The following is a description of a gene set: Human Gene Set: REACTOME_SARS_COV_INFECTIONS SARS-CoV Infections species: Homo sapiens, and this is the list of marker genes: IGHV3-53, ANO5, IFIH1, RPS14, IKBKG, ST3GAL2, CHD4, NUP88, PPIA, GPC3, AKT2, NMI, SIKE1, ATP1B2, JAK1, PIK3C3, IGKV1D-39, SFTPD, TRIM4, AAAS, STT3B, AKT1, GATAD2A, TOMM70, IGHV4-39, PPIH, NUP160, RPS5, PDPK1 (NCBI Gene Id 5170), RPS19, BRD4 (NCBI Gene Id 90616), RPS3, ISCU, NUP58, CHMP4A, RPS23, OST4, FAU, PARP4, UBE2I, CD79B, EEF1A1, UBA52, JAK2, IGLV2-14, TLR2 (NCBI Gene Id 7097), IGLV3-1, IGLV2-8, IMPDH2, IGLV1-51, PCBP2, CHMP6, NUP133, RBBP4, IGLV1-40, RIPK1, RPS29, VPS16, B2M, IFNAR2, TRAF3, NUP107, SDC4, IFNA10, IGHD, IFNA13, TRAF6, RPN2, CHMP3, SAP18 (NCBI Gene Id 10284), BECN1, IFNA21, RPS24, DDX5, FURIN, MOGS, G3BP1, IGKV2-28, PRKCSH, PARP9, PATJ, SMN1, RPN1, RIPK3, GALNT1, TAB1, DDOST, IGHV1-2, GSK3A, STT3A, TMPRSS2, IGHV1-69, HSPG2, HSP90AA1, RPS12, HMG20B, IMPDH1, NUP85, IGKV1-39, IGLV3-25, RPS16, IRF7, ZDHHC5, HLA-C, TJP1, ZBP1, RANBP2, ZDHHC3, FUT8, MAGT1, MGAT4B, IGKV1-5, DAD1, IGKV1D-12, SEH1L, TKFC, CASP1, RPS28, IFNA17, LARP1, UBB, RBX1, KPNA2, IRAK1, TPR, MGAT5, HLA-F, SEC24A, ARID4A, IGKV1-16, GPC1, RPSA, HLA-G, ST6GALNAC4, MTA3, TAB3, ST3GAL1, YWHAZ, STING1, IGKV4-1, SMN2, IGHM, SAP30, RAE1, PARP14, ATG14, ZDHHC2, RPS11, NLRP3, SERPINE1, TLR7, SMAD4, IL17RA, CD79A, RPS2, MTA2, HDAC2, NUP42, NUP93, IGKV3-11, IGLV6-57, CHMP2B, RB1, RPS4X, IGLC2, OSTC, SEC23A, ANO8, BST2, IGHV3-13, MAN1B1, GEMIN7, RPS27L, IGKV5-2, MGAT2, NUP214, NDC1, CHD3, CHUK, IFNA16, IGHV3-48, IGHV2-5, STAT1, SOS1, FXYD4, RCAN3, CANX, RPS3A, ATP1A3, RELA, HNRNPA1, FXYD1 (FXYD domain containing ion transport regulator 1), RIPK2, SH3KBP1, HLA-A, SNRPD3, TLR8, FXYD3, RPS6, RPS26, FNTA, CHMP2A, VPS33B, ATP1A2, EP300, SNRPF, CUL3, SUMO1, HSP90AB1, RBBP7, PARP6, HLA-B, NLRP12, SAR1B, NPM1, IFNGR1, NCK1, IGLV2-23, YWHAE (NCBI Gene Id 7531), GEMIN8, NUP37, RPS13, IGKV1D-16, GEMIN4, AKT3, ANO6, BLNK, ATP1A1, SIGMAR1, RPS25, SNRPE, IGLV3-27, CRBN, SNRPD2, IGLV7-43, IL6R, RPS4Y1, PTPN11, IGHV3-33, ANO2, PARP10, RNF135, VPS18 (VPS18 core subunit of CORVET and HOPS complexes), GEMIN6, SEC24C, CNBP, IGKV3-15, TYK2, ANO10, FXYD7, MGAT4A, PKLR, CTSL, GPC4, RPS10, IKBKE, ACE2, NUP35, SNRPB, YWHAH, IGLV1-44, MGAT4C (NCBI Gene Id 25834), GEMIN5, ANO3, FKBP1A, IGKV1-33, IGHV4-59, TLR9, SNRPG, AGRN, SDC1, RPS17, NPIPB3, SYK, PTPN6, ITGB1, IL17A, YWHAQ, IGKV3D-20, RPS21, AP2M1, RPS7, CREBBP, RPS20, IGKV2D-40, GPC5, SUDS3, IFNAR1, MBL2, MASP1, MAP1LC3B, IGKV2D-28, GJA1, BCL2L1, IKBKB, SNRPD1, IGHV2-70, IFNGR2, GSK3B, IGKV2-30, NUP153, IGHV3-11, ITCH, IFNB1, NUP155, IRF3, SEC24D, NUP210, TUFM, NFKBIA, G3BP2, CHMP7, CHMP4B, PDCD1, S1PR1 (sphingosine-1-phosphate receptor 1), BTK, UBE2N, IGHV3-30, ST3GAL3, ATP1B1, NFE2L2, RCOR1, UBE2V1 (ubiquitin conjugating enzyme E2 V1), ANO1 (anoctamin 1), IGLV1-47, PSMC6, ZCRB1, IGKV1-17 (immunoglobulin kappa variable 1-17), IGKV2D-30, AP2A2, NUP43, PHF21A, GRB2, NUP205, AP2B1, SDC2, IFNA1, SRPK1, SAP30L, SMAD3, NUP62, ARID4B, IFNA5, ROCK1, GATAD2B, ST3GAL4, POM121C, SP1 (Sp1 transcription factor), JAK3, VPS45, RPS4Y2, YWHAB, HAVCR1, ISG15, RPS27A, NUP188 (NCBI Gene Id 23511), PLCG2, VCP, FXYD6, NUP98, CHMP4C (NCBI Gene Id 92421), IL1R1, NOD1, NR3C1, ATP1A4, VPS11, PYCARD, SRPK2, ITGA4, YWHAG, CRB3, ST6GALNAC2, VPS39, MGAT1, IGKV3-20, MAN2A1, STAT2, IRAK2, PARP8, RPS27, MAP3K7, PALS1, TLR1, IFNA2, IFNA14, IGHV3-23 (immunoglobulin heavy variable 3-23), IFNA4, TUBB, EDEM2, ST6GAL1, SDC3 (syndecan 3), CAV1, CSNK1A1, VEGFA, ANO9, RIGI, VPS41, TRIM25, REST, GPC6, RPS15A, NRP1, HDAC1 (NCBI Gene Id 3065), IFNA8 (interferon alpha 8), ZDHHC20, NUP50, ZDHHC9, VPS33A, RUNX1, RPS15, SEC24B, BRMS1, ANO7, IGLC3, ST6GALNAC3, MASP2, FKBP4, NUP54, AP2A1, IGLV2-11, AP2S1, SEC13, RPS9, IGLV3-21, RPS18, HLA-E, MAVS, PARP16, IFNA7, GPC2, IGLV3-19, DDX20, PPIB, CYSLTR1, SFN, NFKB1, IL17F, ANO4 (anoctamin 4), NOD2, IGKV1-12, ATP1B3, PTGES3, UVRAG, PPIG, PRMT1, ZDHHC8 (NCBI Gene Id 29801), GANAB, GEMIN2 (NCBI Gene Id 8487), TAB2, IGKV1D-33, ZDHHC11, IGHV3-7, FNTB, TBK1, UBC, FXYD2, IGHV1-46, KPNB1 (NCBI Gene Id 3837), TMEM258, GOLGA7, COMT, IL17RC, ROCK2, MBD3, VAV1, RPS8, POM121, MTA1, KEAP1, VHL, IGHV4-34, KDM1A, TUSC3, PIK3R4, IFNA6